Given this list of marker genes SIRT1, HPRT1, DPAGT1, ARF4, B3GALNT1 (beta-1,3-N-acetylgalactosaminyltransferase 1 (Globoside blood group)), B4GALT3, GALNT8, ST6GALNAC2, POFUT2, UGT1A10, ST6GALNAC4, ALG3, ZC3HAV1, UGT1A7, POFUT1, UGT2B11, B3GALT2, B3GNT9, B4GALNT1, UGT1A6, ST8SIA3, EXTL1, EOGT, TMTC2, GCNT3, CSGALNACT1, ST3GAL5, B3GALT5, GCNT4, B4GALNT4, EXT2, GALNTL6, UGGT2, MFNG, B3GNT8, ST3GAL2, DPY19L1, B4GALT2, ART4, ABO, PARP12, B3GAT2, DPY19L2, FUT7, GTDC1, ALG9, FUT8, SIRT2, UGT2A3, GBGT1, C1GALT1C1, ALG5, GALNT13, UGT1A8, UGT2B7, ST3GAL1 (NCBI Gene Id 6482), ST3GAL3, AGL, UGT1A1, B4GAT1, STT3B, B4GALT7, ST6GALNAC3, B3GNT7 (UDP-GlcNAc:betaGal beta-1,3-N-acetylglucosaminyltransferase 7), POGLUT1, TMTC4, GALNT3, MTAP, TMEM260, ST8SIA5, ST8SIA6, PRTFDC1, UGT2B17, GALNT2, UGT2B10, GALNT10, A4GALT, EXT1, UGT2B28, ST8SIA2, ST8SIA1, C20orf173 (NCBI Gene Id 730687), MGAT4D, B4GALNT3, PARP9, PLOD1, UGT2B15, CHSY1, ST8SIA4, ALG11, CHSY3, ST6GALNAC1, C1GALT1C1L, TMTC1, EPM2A, PPAT, B4GALT1, GYS2, GALNT16, UGT3A1, DPY19L3, PLOD2, FUT3, ALG13 (ALG13 UDP-N-acetylglucosaminyltransferase subunit), EXTL3 (exostosin like glycosyltransferase 3), ART1, B3GNT5, LACC1, ST6GALNAC5, GALNT11, TMTC3, GALNT1, ALG10B, B3GALT6, PARP4, GLT8D2, UGT1A4, B3GALT4, SIRT4, A4GNT, GCNT1, TYMP, HAS1, APRT, PIGY, MGAT3, UGT2B4, UPP1, UGCG, FUT9, ART5, B3GALNT2, PARP10, B3GALT1, STT3A, GYG1, FUT11, POGLUT3, QPRT, PIGA, GBE1, GBA2, NAMPT, ST6GAL2, GALNTL5, GALNT7, TNKS2, CSGALNACT2, B4GALT6, UGT2A1, MGAT4A, GLT6D1, PARP11, PIGQ, PARP14, ST3GAL4, GALNT9, PLOD3, TIPARP, MGAT5B, GALNT18, B3GAT1, FUT5, TNKS (tankyrase), PIGM, B4GALNT2, MGAT4B (alpha-1,3-mannosyl-glycoprotein 4-beta-N-acetylglucosaminyltransferase B), GCNT2, UGT8, HEXB, UMPS, CHPF2, GALNT17, ST3GAL6, UGT3A2, UGT1A5, RXYLT1, DPY19L2P1, PARP15, UGT1A3, GLT8D1, SIRT3, CERCAM, DPY19L4, B4GALT4, OGT, FUT4, GCNT7, FUT10, PYGL, RFNG (RFNG O-fucosylpeptide 3-beta-N-acetylglucosaminyltransferase), ALG6, LFNG, FUT2, MGAT1, XYLT2, GXYLT2, COLGALT2, CHPF, PYGB, GALNT4, GALNT15, HEXA, POMT2, RPN1, A3GALT2, PYGM, B3GALT9, GXYLT1, GALNT6, ALG1, OSTC, XYLT1, POGLUT2, PIGV, LALBA, ART3, MGAT5, ALG2, PARP3, GYS1 (glycogen synthase 1), ALG10, FUT1, PARP6, GLT1D1, B3GNT2, MGAT2, UGT1A9, SIRT6, XXYLT1, DPY19L2P2, HAS3, UGGT1, UGT2A2, PIGP, DPM1, B3GLCT, PNP, PGAP4, ALG8, ALG1L2, QTRT1, GALNT5, SIRT5, ST6GAL1, B3GAT3, LARGE2, POMGNT2, COLGALT1, RPN2, GYG2, LARGE1, B4GALT5, PIGZ, B3GNT3, HAS2, GALNT12, UPP2, B3GNT4, MGAT4C, PIGB, ST6GALNAC6, PARP1, PARP2, POMT1, PARP8, QTRT2, GBA1, C1GALT1, ALG12, PARP16, B3GNT6, EXTL2, GALNT14, FUT6 (fucosyltransferase 6), B3GNTL1, POMGNT1, here is a description of the gene set: Catalysis of the transfer of a glycosyl group from one compound (donor) to another (acceptor). Human Gene Set: GOMF_GLYCOSYLTRANSFERASE_ACTIVITY species: Homo sapiens